Given this list of marker genes TINF2, ST18, EPC2, NFE2L2, MED1, H2AC16, H2AC15, H1-9P, PRIM1, BRF2, MCM4, SLF1, MPHOSPH8 (M-phase phosphoprotein 8), ING3, TBX5, GATA1, H2AC13, H1-6, EP300, H2AB1, H2AC20, MORF4L1, H1-10, CTC1, TERB1, EPC1, PRM1, CENPA, H2AC19, MCM6, H2BC4, H3-5, TAF10, FOS, CDC5L, H2BC12, SOX12 (NCBI Gene Id 6666), H3C13, POLD3, H2BC3, PCNA, JUP, KAT6A, H3C4, TERF2, RPA4, PRIM2, POLR2H, H2AL3, H2AC17, NPM1, PARP1, H3C10, DONSON, H4C5, H2BC26, H1-4, H4C9 (H4 clustered histone 9), MCM7, EP400, XRCC6, H2AC18, H4C2, IRF4, BRF1, KDM1B, NKX2-5, H2AZ2, GINS2, H3C12, H4C13, H4C4, MYOG, RPAP2, TERF2IP, MEAF6, H2AC25, RPA2, H2BK1, SUZ12, TGM2, MORF4L2, H2BC19P, H3C8, ACD, PRPF19, TONSL, RAG2, YEATS4, RUVBL1, LEF1, H2AB3, RPRD1A, ACTB, PRKDC (protein kinase, DNA-activated, catalytic subunit), H2BC13, ORC3, TERF1, SPHK2, H2AB2, MRGBP, POT1, EYA1, CDC45, H2BW1, H1-5, ACTL6A, H1-8, H3C2, H3Y1, MACROH2A2, H1-2, MACROH2A1, H2BC7, HOXA11, RPRD2, H2BC18, DDIT3, SRCAP, ACTR6, H4C16, XRCC5, JUND, H3C6, H2AP, H2BC10, H2BC12L, H4C3, H3C1, H2BN1, H2BW2, H4C11, TREX1, H2BC5 (H2B clustered histone 5), H2AC1, H3C3, H2AC4, HHEX, RAG1, H2BC9, H1-1, H2AC6, TEAD4 (TEA domain transcription factor 4), RPA3, MCM5, GINS1, H2BC15, ERCC3, GINS4, H1-3, TNP2, POLA2, H3-3A, TNP1, H3-4, RPRD1B (regulation of nuclear pre-mRNA domain containing 1B), H4C6, ERCC5, H2BC14, POLD4, SMARCAL1, KAT6B, H2AC11, PRM3, CTNNB1, H2AZ1, H3C11, BCAS2, H2BC21, MCM3, H2BC6, H1-0, SP3, MCM2, DMAP1, SLC5A8 (NCBI Gene Id 160728), H4C1, H3C7, SHPRH, XPA, H3C15, H2AC7, WDR18, HP1BP3, GTF2H3 (general transcription factor IIH subunit 3), H4C14, RPA1, H3-7, NFYB, GTF2B, STN1, H3-3B (H3.3 histone B), H2BC8, H2AC21, POLD1, TEN1, MBTD1, H2AJ, SP1, RUVBL2, H2AX, VPS72, H4C8, NFYC, ZNHIT1, H4C12, HELB, TOP1, PRM2, NUPR1, RAD52, PAX2 (paired box 2), POLR2M, POLD2, POLA1, ZBTB17, KDM5A, TRRAP, H3Y2, GLYR1, HMGA2, NFYA, H3C14, RECQL5, NFE2, MAX, GTF2A1, H4C15, H4C7, H2BC11, PLRG1, TERT, H2AC8, H2AC12, TCF7L2, BRD8, H2BC17 (H2B clustered histone 17), KAT5, GINS3, H2BC1, ATF6B, here is a description of the gene set: species: Homo sapiens Human Gene Set: GOCC_PROTEIN_DNA_COMPLEX A macromolecular complex containing both protein and DNA molecules.